Given this list of marker genes LILRA4, VAV1, NR4A3, VAV3, MAP3K7, IKBKB, TRAF6, MAPK10, FCER1A, PRKCQ, FCER1G, PLCG1, SYK, MAP3K1 (mitogen-activated protein kinase kinase kinase 1), FER, MAPK8, MAPK9, BTK, MAP2K4, MAP2K7, PLCG2, FCER2, SOS1, LYN, VAV2, here is a description of the gene set: species: Homo sapiens The series of molecular signals initiated by the binding of the Fc portion of immunoglobulin E (IgE) to an Fc-epsilon receptor on the surface of a target cell, and ending with the regulation of a downstream cellular process, e.g. transcription. The Fc portion of an immunoglobulin is its C-terminal constant region. Human Gene Set: GOBP_FC_EPSILON_RECEPTOR_SIGNALING_PATHWAY